Given this list of marker genes FDXR, GLRX5, FDX1, NARF, HSPA9, FXN, NFU1, NFS1, CIAO2B, HSCB, ISCU, NUBP1, LYRM4, NUBP2, ABCB7, here is a description of the gene set: studied in species Homo sapiens Iron-sulfur cluster biogenesis Human Gene Set: WP_IRONSULFUR_CLUSTER_BIOGENESIS